The following is a description of a gene set: NLRP1 inflammasome signaling pathway. Pathway ID: N01567. Pathway type: Reference. Pathway class: nt06521 NLR signaling. Pathway Definition from KEGG: (NLRP1+PYCARD) -> CASP1 -> (IL1B,IL18) Human Gene Set: KEGG_MEDICUS_REFERENCE_NLRP1_INFLAMMASOME_SIGNALING_PATHWAY species: Homo sapiens, and this is the list of marker genes: CASP1, IL1B, IL18, PYCARD, NLRP1